The following is a description of a gene set: Mouse Gene Set: GOBP_L_HISTIDINE_METABOLIC_PROCESS species: Mus musculus The chemical reactions and pathways involving L-histidine, 2-amino-3-(1H-imidazol-4-yl)propanoic acid., and this is the list of marker genes: Mthfd2l, Amdhd1, Mthfd1, Ftcd (formiminotransferase cyclodeaminase), Hdc, Uroc1, Hal